Given this list of marker genes GSK3B (glycogen synthase kinase 3 beta), MECP2, KCNQ4, PAN3, DDX6, FIGNL1, FHOD3, ALDH5A1, DYNC1I2, RAB5IF, SLC1A2, POU2F1, COL4A4, TOP2B, NRBP1, ZNF267, ZNF33A, GRIP1, CYP2U1, PCDH11X, RHBDL3, VPS13A, YY1, CARD17P, BICD1, GSG1, TSPAN7, CEP350, ZNF704, ZNF518A, WWP1, TMF1, RICTOR, APOB, TOX3, HECTD1, CLCN5, TULP3, GPAM, SDC2, AS3MT, TAB3, DDX5, ZFAND5, PCGF2, C11orf58, PLEKHF2, EGFR (NCBI Gene Id 1956), HIVEP3, DDO, BBIP1, BCL3, CNDP1 (NCBI Gene Id 84735), ALG9, TENM3, SLC39A1, MMP24, PALM2AKAP2, NAT8L, PECAM1, SLC35F1, MYLIP, MARCHF4, MAT1A, CELF5, PLGRKT, FGF12, ETS2, YEATS4, DIDO1, LALBA, KLF12, MIER3, FAM229A, LIMCH1, TIAL1, B3GAT1, C18orf63, KLF9, RIMS1, STK35, FOXN3, KLHDC10, FGFRL1, PHTF2, TTC39C, ADAMTS3, SLITRK6, ZDHHC2, CLK3, COA5, SLC38A1, MEA1, PDAP1, CEP85L, MED23, APLP2, CADM2, ZZZ3, SLC9A6, PUM2, ANKRD44, POC1B, C11orf87, CHMP2B, DCAF10 (DDB1 and CUL4 associated factor 10), JCHAIN, FAM78A, SP4, IER5, ARRB1, SRCIN1, CHD6, TLCD4, UBN2, SPRED1, SAMD12, SCN4B, ESAM, NUDT5, MAST4, KCNF1, TRARG1, EPB41L5, TAC1, USF2, ACAD10, NRK, FGF14, TMEM132B, ELK4, PSME4, NAMPT, VIRMA, FEM1A, ATP10A, PALLD, BIVM, TMEM187, CXXC5, ZFHX3, PHF21A, OGT, USP31, SLC1A4, MBNL1, ZNF275, MBD6, SLC11A2, SCAI (suppressor of cancer cell invasion), CDC6, LIFR, CA2, ATXN2, STAU1, LMNB1, ZMYND10, SKIL, FAM53A, ZDHHC11, DICER1, FKBP10, RASSF5, CALN1, PHF13, BCHE, NCAM1, PCDH8, DTNA, here is a description of the gene set: species: Homo sapiens from publication Chen Y, Wang X (PMID 31504780) Genes predicted to be targets of miRBase v22 microRNA hsa-miR-5008-3p in miRDB v6.0 with MirTarget v4 prediction scores > 80 (high confidence targets). Human Gene Set: MIR5008_3P